Given this list of marker genes ULK1, NEK6, TNK1, BMX, KIT, VRK2, FES, MAPKAPK5, FER, MAP3K9, MEX3B, MAP2K2, ABL1, STK24, IGF1R, EPHB4, NTRK2, VEGFA, CHEK2, TSSK2, MAPK15, EIF2AK2 (NCBI Gene Id 5610), MAP3K11, STK11, MAP4K1, STK26, PDPK1, MVP, EPHB1, INSR, MELK, FLT3, MOB1B, CSF1R, ULK2, IRAK1, RIOK2, DDR1, ERN1, OXSR1, LRRK2, LTK, NRG1, MAP3K21, MUSK, MAP3K13, GRK7, PASK, MAPK3, TAF1, FLT1, ERBB4, GRK1, MINK1 (misshapen like kinase 1), HCK, EIF2AK4, STK16 (serine/threonine kinase 16), MARK2, CAMKK2, DDR2, STK10, NEK10, STK17B, RAP2A, TOM1L1, MAP3K12, PTK2, EPHA7, MAK, GSK3B, SLK, MYO3A, CAMK2A, CHP1, RASSF2, GRK5, MYLK2, INSRR, EPHA4, SIK2, PRKD1, MAP3K10, RIPK1, PIKFYVE, PTK6, EEF2K, PDGFRA, ACVR1B (activin A receptor type 1B), ERRFI1, NEK2, STK33, DAPK3, AKT1, SRMS, PAK2, PRKX, VRK1, SRC (NCBI Gene Id 6714), NTRK1, PIM1, FGFR4, DAPK1, WNK2, EIF2AK1, FGR, SIK1, TNIK, PDGFB, PDGFRB, KDR, CLK2, AURKA, HTATIP2 (HIV-1 Tat interactive protein 2), FLT4, ULK3, FGFR2, CAMK2B, LCK, LYN, MAP3K20, STK4, STK39, PDGFA, MAP3K3, ALK, TRPM7, SMG1, TXK, TNNI3K, FGFR1 (NCBI Gene Id 84151), ATM, PTK2B, PEAK1, ADIPOQ (NCBI Gene Id 9370), STK25, JAK2, DYRK1A, LMTK2, DAPK2 (death associated protein kinase 2), EPHB3, here is a description of the gene set: Human Gene Set: GOBP_PROTEIN_AUTOPHOSPHORYLATION The phosphorylation by a protein of one or more of its own amino acid residues (cis-autophosphorylation), or residues on an identical protein (trans-autophosphorylation). studied in species Homo sapiens